The following is a description of a gene set: Human Gene Set: REACTOME_REGULATION_OF_RAS_BY_GAPS studied in species Homo sapiens Regulation of RAS by GAPs, and this is the list of marker genes: PSMD14, PSMA2, SYNGAP1, CUL3, RASA4, NRAS, PSMB6, PSMC5, SPRED1, PSMD12, DAB2IP, PSMD2, PSMC3, PSMC1, SEM1, SPRED3, PSMB2, PSMD3, PSMB4, RBX1, PSMA3, PSMB1, PSMB5, SPRED2, PSMA6, RASAL1, KRAS, RASAL2, PSMD8, PSMA5, PSMA7, RPS27A, UBC, PSMC2, RASA2, RASAL3, ADRM1, HRAS, PSMC6, PSMA4, PSMB3 (proteasome 20S subunit beta 3), PSMB7, RASA1, NF1, PSMA1, RASA3, PSMD11 (proteasome 26S subunit, non-ATPase 11), PSMD7, PSMD13, PSMC4, PSMD6, UBB, PSMD1, KBTBD7, UBA52